The following is a description of a gene set: Mouse Gene Set: HEVNER_HIPPOCAMPAL_CELLS from publication Bedogni F, Hevner RF (PMID 34321999) Genes selectively expressed by hippocampal region cells in embryonic day 14.5 mouse telencephalon. species: Mus musculus, and this is the list of marker genes: Bdnf, Prox1, Galnt14, Synpr, Slit2, Dmrt3, Dmrta2